The following is a description of a gene set: Human Gene Set: GOBP_POSITIVE_REGULATION_OF_PHOSPHORUS_METABOLIC_PROCESS studied in species Homo sapiens Any process that increases the frequency, rate or extent of the chemical reactions and pathways involving phosphorus or compounds containing phosphorus., and this is the list of marker genes: XRCC6, PRKAA2, SYAP1, LIMCH1, GPLD1, MAP3K5, ENPP2, CALCA, RAP1A, TGFB1, CD4, P2RX7, IL11, ARHGEF5, MAPK1, THBS4, RARRES2, CDK2AP1, KDR, WNK3, MTOR, SPHK1, LCP2, DHX34, CARD14, HTR2C, PID1, ATG14, ERBB2, FAXDC2, GRB10 (NCBI Gene Id 9769), CD80, CD74, FGF10, RAF1, MLST8, LAT, GAS6, COPS8, TLR3, EREG, CNTF, NRG1, EFNA5, TLR6, GUCA1ANB-GUCA1A, AGAP2, ACSL3, PTPN1, CCNY, RALBP1, KIF14, MUSK, RALB, PTH1R, CHI3L1, ZNF268, RACK1, CENPE, TNFRSF10B, CD244, MIF, INS, ELANE, TNFSF18, EGF, INSR, BEND3, TCIM, PRXL2C, ADCYAP1, LYN, IL4, PIM1, LILRA5, VEGFB, UBE2K, TRIM6, NDUFC2 (NADH:ubiquinone oxidoreductase subunit C2), NRP1, MAP3K11, HES1, CTF1, FGF2, RIPK2, ITLN1, MLXIPL, BCL10, SRCIN1, NIBAN1, GLMN (NCBI Gene Id 11146), HDAC3, EEF1A2, ARNT, GPER1, TOM1L1, CLSPN, PINK1, WDFY2, GUCA1A, ENPP7, HLA-DRB1, IL12A (NCBI Gene Id 3592), VEGFA, ADORA1, CNOT9 (CCR4-NOT transcription complex subunit 9), FLT1, PPIA, ERBB4, IRGM, AVPR1B, TNIK, PLAUR, PSEN1, GAPDHS, JTB, ADAM17, ACVR2A, ADGRF5, STRADA, RIPK3, EFNA1, CRIPTO, MMD2, TMSB4X, SDCBP, FLT4, RASGRP1, FBN1, FGF19, RAP2A, DIPK2A, C3, ETAA1, SASH1, APOC2, ERCC6, P2RY1, TREM2, PRKCD, ZNF16, PTPRC, KCTD20, VCP, DIRAS1, BRAT1, OSM, WNT5A, DYNAP, RAB38, LEP, MST1R, CLIP3, SPRY2, NPTN, RHOA, SNCA, BRAF, ARHGEF2, CHP1, APP, FGFR3, ADCYAP1R1, ITGB1BP1, BMP4, NEDD9, RSPO1, PDGFA, DRD4, TAFAZZIN, IL18, CREBL2, TPD52L1, MMP9, IL6, STRADB, S1PR2 (NCBI Gene Id 9294), TNK2, ANG, IFNG, IL31RA, MAD2L2, UNC119, FLT3, PTH, PSMD10, PDGFB, SIRT1, IL20, CHP2 (calcineurin like EF-hand protein 2), BMP2, CACUL1, EGFR, ODAM, CCDC88A, SRC, PRLR, TNFRSF18, MAP3K10, CAPN2, TNFRSF10A, NEK10, PPARA, NTSR1, PILRB, DOK7, CAMK1, TAOK3, FABP3, ADCY10, RAPGEF2, FGFR1, CASS4, MAP2K3, ZBTB20, IL15, PFN2, IL21, GPRC5B, LMO4, JAK2, ARL2BP, RASSF2, P2RY6, SLC4A4, STOX1, SNX9, PIH1D1 (NCBI Gene Id 55011), THPO, FZD7, PRKAA1, MAP2K2, PARP9, LACRT, FGF1, GPD1, PTK2B, PELI2, DDRGK1, PARP14, PDCD10, WEE2, FBH1, NR1H4, CARD10, FGF7, ERN1, MAP2K1, STAT3, KAT2B, MMD, ADCY8, ROCK2, ARRB1, RAC1, IFNL1, PDGFRB, STK11, APLN, HTR2A, TAB2, MYDGF, S100A12, MAP3K7, AKTIP, TPX2, PTK2, HTR2B, FLOT1, LTF, PIK3R5, MAP4K2, AKT1, TIGAR, MAP3K4, ENO1 (enolase 1), UCHL1, FGF18, HMGA2, FAM20A, KIT, ABL1 (NCBI Gene Id 25), TNF, KNDC1, PIBF1, TRAF6, DIRAS2 (DIRAS family GTPase 2), TNFSF15, STK4, CEMIP, DSCAM, HIF1A, ABI1, ANGPT4, THBS1, ARAF, SPDYA, DDR2, MRNIP, CDKN1A, XRCC5, ADIPOQ, BANK1, ANGPT1, RIPK1, DSTYK, IL34, MTMR9, PROM2, TBX1, ZFP91, ZNF622, EZH2, TRAF2, ECT2, SPATA18, CSF1R, LIF, CIB1, PRKN, SEMA4D, AREG, IGF1, PIN1, PIK3CG, LHCGR, PIK3R6, ALS2, CIMAP3, TENM1, TRAF4, XBP1, CAB39, CSPG4, MT3, RPTOR